Given this list of marker genes Commd1, Gm15418, Prnd, Fam47e, Gm22206, Lrfn2, Yars2, Pcdhb22, Celsr2, Mertk, Tns3, Ric8b, Crybg2, Dcst1, Ttll6, Zcwpw2, Tap2, Polr1f, Farp1, Nedd4l, Brpf1, Tle1, Vwf, Atad2b, Ccdc12, Dennd10, Tgfb3, Ndufs6b, Nme1, Gm12315, Stimate, Smim45, Gm13974, Gadd45b, C2cd4b, Kifc3, Calhm5, Iqcg, Epb41l4a, Tm4sf5, Snrnp35, Gm26436, Gm9385, Gcc1, Cog1, Eif1b, Dclre1a, Gm49405, 1700003M07Rik, Syn3, Ccny, Zfp74, Enho, Pfkfb3, Cnnm2, Odad3, Abca4, Npr1, Spata3, 4930412C18Rik, Gm12034, Serhl, Cep135, 1700072G22Rik, Rnf139, Dalrd3, Parp3, Rnasel, Gm11725, Zfp143, Gm6610 (NCBI Gene Id 634864), Gm25604, Pts, Lcp1, Gart, Exosc4, Sh3bgrl2, Sbk2, Htr1a, Trappc3, Zc3h14, Aatk, Atp1b3, Ash2l, Ido2, Alg9, Ncmap, Gm5432 (NCBI Gene Id 432636), Pcdhb19, 2310001H17Rik, Spef2, Esr2, Chtop, Faxc, Snai1, Gm3809, Samd9l, Dlgap5, Chmp1b2, 4930432E11Rik, Tpm1, Pcdhac1, Bdh2, Txlnb, Ube2g2, Cebpd (NCBI Gene Id 12609), Morc1, Selenom, Enc1, Ube2l6, E330013P04Rik, Hsd17b14, Tnni3, Limch1, Sgk1, Eva1c, Ppp1r37, Ddah2, Ltbp1, Scara5, Txnrd2, Gm22018, Pou2f2, Mrpl17, Marchf11, Spc24, Nsfl1c, Pcgf1, Lrig2, Smarce1, Dpp6, Grik4, B230207O21Rik, Tsc22d3, Clcn2, 9530052E02Rik, Wdr41, Cfap100, Brf1, Hoga1, Ypel1, Kcna7, Slc6a21, Ppdpf, Slc38a10, Unc45a, Gm23946, Trex1, Gda, Slc25a45, Smim11, Amz2, Gnl3l, Prdm1, Nlgn1, Tmem82, Pdxdc1, Esf1, Gm16271, Adra1d, Gm23432, Sec14l2, Sft2d1rt, Cic, Arl1, Pcp4, Ror1, Gpaa1, Adam33, Dram1, Trim45, 9130213A22Rik, Prcp, Cmss1, Gm12514, Trpc3, AW495222, Nes, Grin2c, Pknox2, Lingo1, R3hdm1, Tekt5 (NCBI Gene Id 70426), Top1mt (NCBI Gene Id 72960), Gm23440 (predicted gene, 23440), Ago2, Ephb6, Yjefn3, Srcin1, Krtcap2, Gm25261, Nrxn2, Grep1, Mfsd4b4, Furin, Fbxo8, Pear1, Gm31243, Aadat, Arf4, Casp2, Styk1, Pgam5, Ulk1, Smarca5, Gm34767, Setd5, Gramd1b, Mpo, Btbd16, Rwdd3, Myg1, D6Wsu163e, Nkain2, Slc2a1 (NCBI Gene Id 20525), Alkbh7, Itga6, Raf1, Olfml3, Arhgef2, 0610031O16Rik, Gm12712, Ppp2cb, Traf5, Pcdhga10, Col1a1, Med23, Ggt7, Yju2b, Parp11, Atp7a, Mapkbp1, Hook2, Sag, Acin1, Ap5s1, Cfap46, Gm13031, Hhat, Tmem14a, Zdhhc1, Kif26a, Arrb2, Uqcc2, Tsc22d1, Ror2, Rtl9, Gm14017, Gm17952, Hivep3, Iqsec1, Cpne5, Gbp5, Cntfr, Ube2l3, Ect2l, Gm25148, Ttc19, Zfp607b, Hapln2, Adgra2, Garem1, Lmna, Psmc4, Gm26104, Smc3, Tafa2, Gm18036, Brsk2, Ywhae, Garin1a, Ttpal, Ush1g, Gm17552, Ephb1, Med27, B4galnt1, 1700069L16Rik, Gm37885, Tmem242, Tmem259, Npy1r, Ttc39a, Dgcr6, Tor2a, Ghr, Hgfac, Cryba2, Fam83h, Rhof, Slc9a1 (NCBI Gene Id 20544), Slc6a19, Ptpn22 (NCBI Gene Id 19260), Sigmar1, Csrp1, Adamtsl5, B9d1, Dus2, Gbf1, Sorcs2, Gpr108, Catip, Zyx, Tent5d, A230077H06Rik, Gm24469, Dst, Endov, Cacna1s, Emg1 (EMG1 N1-specific pseudouridine methyltransferase), Xndc1, Timm23, Akap7, Ppp1r14a, Ncf4, Elob, Dohh, A330023F24Rik, Tent4b, Cep44, Mir449c, Zfpm1, Lix1, Itga4, Ercc4, Mink1, Man2b2, C1ra, Gm34583, Apobec3, C030014I23Rik, 4930509H03Rik, Trim30b, Csmd3, Tnfaip8l2, Sema4f, Nfkbil1, Zzz3, Rusc1, Col26a1, Irak2, Harbi1, Nme9, Gnptab, Ncoa2, Pitpnm1, Gm35507, Rnf43, Zfp1004, Itgal, Cdh24, Cblc, Gm11342, Sh3d19, Fam171a2, Gm20610, Hsd3b7, Zfp51, Slc52a3, Gm17767, Tbc1d1, Faap20, Ints14, Ddx54, Gm22778, Caskin2, Rrp9, Nucks1, Icam2, Cabp2, Cfap54, Prp2rt, Ppip5k1, Gtf2ird1, Glis2, Npas2, Atf7ip, Gm22827, Adra1b, Atg101, Tmcc2, Cep164, Rapgef3, Slc35f1, Prorp, Acbd4, Mcmbp, Asb4, Piezo1, Fabp12 (NCBI Gene Id 75497), Timm22, Cdk5rap3, C1rl, 2310069B03Rik, Gm18444, Urod, Aox3 (NCBI Gene Id 98316), Rgs9, Lsmem1, Gm7168, Haus7, Tmem40, Gm13832, 9430087J23Rik, Smagp, 2600014E21Rik, Anapc7, Kmt2b, Acvr1c, Yipf6, Gins4, Dap3, Smg9, Shank3 (SH3 and multiple ankyrin repeat domains 3), Magohb, Zim1, Rnps1-ps, Ms4a19, Gm8501, Or52n4, 4930402F06Rik, Itga8, Islr2, Scarb2, Slc2a4, Septin9, Wnt7a, Exoc1, Mc5r, Plxna2, Atp8b5, Kctd15, 4930447M23Rik, Erap1, Dxo, Glipr2, Gimap8, Adap1, Atf6, 9930004E17Rik, Gm11175, Slc1a2, Gm2287, Rcc2, Gm10143, Sik2, Srl, Gm3336, Zfp868, Socs3, Gm11196, Gm4775, Tmem163, Frs3, Pcdhb16, Yars1, Acap3, Gm9936, Tsc22d4, Tyw5, Rbm4b, Eci2, Tctn1, Plk2, Gm23745, Pklr, 1600014C10Rik, Scgb1c1, Adra2b, Klc2, Rapgef1, Tlcd1, Rxfp3, Hoxc10, Sema3b, Mecr, Trav8d-2, Pde12, C330018A13Rik, Gm22881, Eif2b1, Palld, Kdm1b, 4930503O07Rik, Atp6v1g2, Ehd2, Ankrd44, Lsm11, Gm13025, Nav1, Ddx24, Armc8, Gh, Frg1, Dusp23, Gm15958 (NCBI Gene Id 100503546), Angel2, Mif-ps6, Capn8, Man2a1, Grin2b, Gm25758, Rp31-ps19, Ccdc42, BC028471, Dhx32, Gm25093, 4930519G04Rik, Gm42579, Pdgfrl, Atp2c2, Pafah2, Rab27a, A430048G15Rik, Pde4d, Tbl3, Gm17382, Ess2, Crybg1, Hipk4, Cenpx, Mir6380, Atp5f1d, Pcdh1, Gadd45g, Gm2093, Stk19, Mir7055, Iscu, Rbm3os (RNA binding motif protein 3, opposite strand), Tnk2os, Abt1, Gm13388, Zfp949, Gm20655, Vcan, Ezh1, Tmem108, Trgv7, Prr33 (NCBI Gene Id 677289), Cc2d2a, Ppp2r3c, Reln, Lpin3, Gm12273, Unc13b, Kctd18, Sult6b1, Ccbe1, Atp2c1, Lrrc24, Cyp2w1, Rbp7, Esyt2, Gstm1, Mnd1, 4930568A12Rik, Gm14010, Myo7a, Abca14, Gm28513, Thumpd1, Tmem220, Noc4l, Rnf150 (NCBI Gene Id 77483), Trpm5, Blcap, Cstdc2, Gm22245, Gm19412, Mllt1, Fgd6, Zcwpw1, Gm9701, 4930597A21Rik, Gmfg, Trav3-4, 1700109G15Rik, Slc6a8, Trmu, Prss48, Napa, App, Slco3a1, Zfp746, Gjc2, Ccdc88c, Alcam, Ciao3, Nup133, Nudt17, Slc5a8, Ctnna3, Gnaz, Epb41l4b, Wnt11, Nufip2, 4930451I11Rik, Klhdc9, Mir2861, Tinf2, Gas2l1, Gm9005, Gtf2h3, Mettl21a, Fmnl3, Gnas, Elf3, Ccr5, Gm25938, Dhx57, Tsga10, Diaph1, Rgcc, Acot11, Mir193a, Nr1i2, Gm26911, Camkk2, 1700001L05Rik, Slc23a2, Park7, Megf10, Hdc, Nop14, Bmp1, Gm43464, Polr3gl, Ighv1-86, Wdr38, Ctu2, Afp, M6pr, Senp3, Zfyve27, Adprs, Gypa, Snrpe, 1700007F19Rik, Gm8146, Bcl2l1, Gtf2h2 (general transcription factor II H, polypeptide 2), Plcb1, Cystm1, Gm13652, Tysnd1, Gm29610, Clec4d, Ciart, Srbd1 (NCBI Gene Id 98081), Nfx1, Gas7, Fgf15, Ap2s1, Glipr1l1, Mtnr1a, Fam136a, Zfp800, Cdk18, Mbip, Vps13d, Prkag2, Cfap97d1, Ankrd2, Tmc8, Pkn3, Flnb, Bltp2, Idh1, Trappc3l, Nob1, Grn, Gm10253, Edn1, Il20ra, Mrpl38, Spmap2, Map3k6, Psg16, Mcm5, Ppm1j, 1700028E10Rik, Irf7, Gm2109, BB014433, Arhgef10l, Spen, Gm23856, Cideb, Ddo, Tdrd5 (tudor domain containing 5), Arhgef16, Coa7, Rgs20, Drd1, Tsen54, Crip1, Poc1a, Lrrc7, Bmal1, Ctsr, Gm26812, Gm42922, Gm16184, Rbfox3, Flvcr1, Gm24334, 2410004B18Rik, Tgfb1i1, Asnsd1, Rubcnl, Pdlim2, Gm4279, Brd10, Clu, Mir3960, Eif3f, 1700072B07Rik (NCBI Gene Id 73529), Cpt2, Comtd1, Fbl, Dnmt3b, Ddias, Zfp692, Son, Ccdc13, Cacnb3, Ctnnb1, Prss36, Parl, Lsr, Gm33051, Nifk, Gfi1b, Coro2a, Atg13, Spns1, Cmah, Carmil1, Adra2a, Cemip, Gm14161, Parm1, Ryr2, Ccdc153, Ggnbp2, Tmem33, Lgi4, Rtn4r, Mir6919, A230108P19Rik, Dixdc1, Mlf2, Gm15401 (NCBI Gene Id 100038714), Ankmy2, Slc25a38, Pold1, Scnn1g, Rhoay-ps3, Sds, Mgat5b, Chrm5, Rbak (NCBI Gene Id 57782), Timm9, Fancc, Telo2, Nepro, Sema3f, Scai, Pfn4, Eid2b, Bambi, Gm11532, Ankrd6, Sfswap (NCBI Gene Id 68937), Phlda1, Apmap, Gdf5, Wdr83, Tnnt3, A830082K12Rik, Rnd3, Gm26885, Clcc1, Gm10610, Katnal1, Rpl21-ps11 (NCBI Gene Id 433630), Pcdhb14 (protocadherin beta 14), Gm16133, Col23a1, Rbis, Gbp3, Lhfpl7 (NCBI Gene Id 333048), Erlin2, 2410004P03Rik, Usp38, Elf5, Pld2, Snx15 (sorting nexin 15), Reep4, Pak4, Gm29704, Nlrx1, Hnrnpm, Ankrd39, Magi2, Tbc1d9b, Gm11100, Arhgap26, Slc35e4, Foxs1 (forkhead box S1), Adamts17, Cyp21a1, Gm25631, Zfp663, Slc7a7, A630001G21Rik (NCBI Gene Id 319997), Lrrc3c, Gm10825, Gad1, Trim69, Cln5, Man2c1, Pink1, A730011C13Rik, Dnajc13, Amigo3, Edrf1, Mup-ps17, Flot1, Gm20658 (predicted gene 20658), Gm22927, Olfm1, 1700047G03Rik, C2cd3, Rad51d (NCBI Gene Id 436461), Rpp30, Lyzl6, Ski, Slitrk5, Cfap157, Gm831, Tmem11, Lrrc27 (leucine rich repeat containing 27), Ache, Tmod2 (tropomodulin 2), Nckipsd, Zc3h6, Sphk1, Arhgap22, Gm26352, Trip10, Cryzl2, Ovca2, Gm16144, Rmnd5a (NCBI Gene Id 79046), Arl4aos, Gars1, Agpat3, Rcc1, Cyp21a2-ps, Cd164, Gm20443 (NCBI Gene Id 118568333), Kyat3, Pou2f1, 1700128E19Rik, Sult1d1, Gpx8, Gm4925, Dact3, Msantd1, Npdc1 (neural proliferation, differentiation and control 1), Gm11444, Nmbr, Best1, Cul9, Itga9 (NCBI Gene Id 70107), Car2, Rpl5-ps2, Gm28836, Erich2, Arhgap18, Zng1, Rpgrip1, Cabin1, Mterf1a, Mir187, Cdc14b, Adcy10, Gpsm1, Pdgfra, Bach2os, Tph1, Gm40332, Dcaf11, Suds3, Nudt1, Sox13, Stum, Gm17508, Csgalnact1, Pdhb, Pdzd9, Pitpnm3, Gm9978, Slc25a22, Gm15408, Bcl6b, Vta1, Abcb8, D330050G23Rik, Abr, Plxnb2, Alox12e, Sh3kbp1, Wdr1, Mir7672, Mir497, Sec11c, Cbarp, Ubxn11, Fntb, Atp2b4, Chrna1os, Lbh, Snx18, Nbeal2, 4632415L05Rik (RIKEN cDNA 4632415L05 gene), Chrdl2, Gm9929, Eid2, Lrrc66, Gm14330, Etv5, Kcp, Trmt61b, Hmgb1-ps6, Tmem200a, Twf1, Gm23748, Otop2, Gm42935, Mir6944, Ahcyl1, Tomm5, Tbx3os2, 1810044D09Rik, Ttc24, Cgnl1, Rtn4rl1, Gm11998, Tshr, Mc3r (NCBI Gene Id 17201), Smim29, Map4k5, Kcnk13, Mir8109, Arl4a, Pag1, Cog4, Ephb3, D5Ertd615e, Snx14, Aire (autoimmune regulator), Gse1, Ccin (NCBI Gene Id 442829), Dnai2, Ppp1r9a, Notum, Tmem102, Gm12494, Fgd5, Gm25726, Alkbh4, Rita1, Pias3, Gm10039, Ptpre, Vezt, Spry4, Znrf1, Man2c1os, Txndc5, Coq8b, Glra2, Ninj2, Focad, Dcbld2 (discoidin, CUB and LCCL domain containing 2), Cdk9, Inka1, Mir759, Mmp17, Capg (NCBI Gene Id 12332), Trpv2, Crbn, Gm30382, Tcerg1l, Elmo1, Gm9989, Ppox, Atp8b2, Chct1, Psmc3, Gm26225 (NCBI Gene Id 115488410), Phf8, Gm3764, Ccdc177, Bid, Trappc5, Adam15, Npff, Gabpb1, Dtx4, Gm12925, Gm26802, Gm38171, Rtca, Ptpru, Mfsd4b3-ps, Gcnt1, Mir7653, Socs1, Fmnl1, Carf, Commd7, Cpeb1, Cenpu, Kcnj6, Asic5, Tedc1, Taf1c, Fkbp14, Rufy4, Sptan1, Mrgpre, Mir669n, 1700054O19Rik (NCBI Gene Id 74272), Sdk2, Rnf7l, Idua, Gm10224, Steap1, Pcdha12, Hoxd3os1, Timm44, Spr-ps1, Rnf123, Rbpms (RNA binding protein gene with multiple splicing), D930020B18Rik, Gm1720, Rapgef4os1, Rprm, Efna1, 0610040F04Rik (NCBI Gene Id 75394), Acacb, Clip1, Gm26406, Ndor1, Csnk1a1, Mycn, Sec31a, Mro, Myof, Podxl2, Camk1d, Ftx, Nemp2, Pxn, Robo3, Tfip11, Tph2, Kdm2b, Mir100hg, Mogat1, Cirbp, Rnd2, Igsf9, Uba1, Klf13, Fryl, Gm6361 (NCBI Gene Id 632710), Gm30484, Megf8 (NCBI Gene Id 269878), Pidd1, Fam222a, Azi2, Suox, Slc39a13, Mmp9, Ctdsp1, Hoxa7 (NCBI Gene Id 269740), Cacna1e, Bscl2, Ptpn18, H4c11, Zpbp2, Hcar1, Rab37, Ptpa, Otos, Cpne4, Gm23774, 6530411M01Rik, Sgf29, Gm42109, Zfp345, Ntrk1, Grk5, Pik3r5, Armc6, A930015D03Rik, Gm11420, Mipol1, Trp53rkb, Gm8186 (predicted gene 8186), Gm24335, Prkcz, Map3k5, Atp9a, Ramp1, Gm25009, Hcrtr1, Katnbl1, 2010204K13Rik (NCBI Gene Id 94037), Gm29387, Nelfa, Ndufaf6 (NADH:ubiquinone oxidoreductase complex assembly factor 6), Pdgfd, 1700045H11Rik, Scn3a, B3gnt3, Gm7094, Afap1l2, Epha1, Tgif1, Rad51ap1, Smarcd3, Rab13, Slc22a15, Exd1, Cebpb, Nup42, Tlr6, Myo18a, Rpl7l1, Etos1, Dhx30, Mrpl52, Gm16459 (NCBI Gene Id 671250), Czib, Notumos, Tnfrsf21, Gng7, Gm23437, Sell, Rhcg, Slc16a11, Ccdc192, Gap43, Kdm6bos, Pga5, Bzw2, 4632404H12Rik, Hsp90aa1, Alpl, Dip2b (disco interacting protein 2 homolog B), Rtn2, Gm32585, Pcdhga11, Tnfaip3, Grk2, Gm12411, Aipl1, Gm27008, Wif1, Pex10, Airim, 4833412C05Rik, 9330175M20Rik, Cep63, Pla2r1, Clec4g, Rai1, 1500015L24Rik, Pvr, Tank, Cilk1, Ceacam23, Tmem270, Npc1, Prkcsh, Etv4, Rnf215, Cdh23, Car5a, 1700030A11Rik (RIKEN cDNA 1700030A11 gene), St8sia1, Gm36070, 2410124H12Rik, Synj2, Arhgap27, Rasd1, Cyp2j15-ps, Mfhas1, Itih1, Sgsm3, Cxcr4, Slc36a1, Pdk2, Ube4a, Mttp (microsomal triglyceride transfer protein), Adam11, Mrpl39, C1qtnf1, Stag1, Gm24998, Eif2ak1 (NCBI Gene Id 15467), Gm43380, Gm15651, Npl, Etnk1, Mettl2, Prickle4, Rbm17, Kirrel1, Hectd3, Adgre5, Rbm46, Cntn2, Eif4g2, Mep1b, Spmip7, Larp7, Zfp36l1-ps, Astl, 1700034H15Rik, Gm18330, 4930573C15Rik, Clec2d, Oma1, Psen2, Srsf3, Ccdc38, Spata20, Tmem191 (NCBI Gene Id 74063), Rac3, Nt5c1a, Pigz, Rnf166, Gm13506, Gm24580, Pex1, Plekhg2, Gm24751, Gm3086, Gm4784, Mir195a, Irag1 (NCBI Gene Id 233729), Gm11378, Ablim1, Lrrc15, Amdhd1, 4930463O16Rik, Stk10, Sema3c, Slitrk6, Gm24433, Fuca1, Mfsd4a, Trpm8 (transient receptor potential cation channel, subfamily M, member 8), Atp11a, Pou2f3 (NCBI Gene Id 18988), Mir7235, Snord3b-ps2, Rrp1, Gm11638, Ppp1r12c, Ctc1, Sh3bp5, Scn2a, Tns1, Socs2, Zfp638, Ccng2, Cemip2, Fam185a, Ccdc85a, Slc29a1, Mob3b, Slc12a9, Trmt1, Chd9, Gm12069, Gm25345, Gna14, Tfap2c, Zfta, Ube2q1, Rnf19b, Cdkn2aipnl, Lig4, Rbm3-ps, Cxcl3, Rab32, Trim46, Antxr1, Hoxc5, Inpp4b, Asgr1, Cldn1, C1rb, Phlpp1, Dnm3, Prlr, D5Ertd605e, Atl1, Dhx8, Nectin2, Mroh7, Nuf2 (NCBI Gene Id 98608), 4930521E06Rik, Dusp13b, Chadl, Dpysl3, Inafm2, Coq2, 5033423K11Rik, Ablim3 (actin binding LIM protein family, member 3), Ahcyl2, Mycl, Nsg2, Rpl18a, Gm24794, Dnah17, Sh3glb1, Mrpl33, Ccdc83, Plekha6, Gm5614, Gnai2, AA474408, Myo1h, Galt, Gm23609, Tmem42, Cdkn2a, Vsir, Elapor1, Fmod, Vegfa, Rpl13a, Gm26671, Tmem199, Gm11465, Ripor2, Med12, Tex48, Slc38a8, 2310015A10Rik, Setd1a, Ddx51, Gm650, 2700049A03Rik, Errfi1, Cfap276, 4930447F24Rik, Sucla2, Zfat, Nceh1, Tent5b, Abca15, Pcyt2, Mafb, Pcdhgb7, Zfp469, Lgr6, Dop1b, Ccdc124, Otud5, Coro7, Pcdhb21, Nhlrc2, Pcdhgb8, Gm11422, Gm24457, Adprhl1, Ahrr, Cntrl, Nprl3, Vps18, Grm8, Prodh2, Gm12602, Uck1, Phb2, Zfp54, 0610040J01Rik, Kcnh1, Gfap, Gm12320, Mir1668, Ifngr2, Spock1, Gask1b, Hnrnpd, Mfn1, Atn1, Gm24793, Gm13778, A830008E24Rik, Col6a2, A330048O09Rik, Plxna1, Cuedc1, Chp1, 4921539H07Rik, Gm11954, Fhod3, Fcmr, Rps19-ps10 (NCBI Gene Id 676683), Dnajc22, Zfp764, Als2, C3, here is a description of the gene set: Genes containing one or more binding sites for (Zc3h11a) in their promoter regions (TSS -1000,+100 bp) as identified by GTRD version 20.06 ChIP-seq harmonization. studied in species Mus musculus Mouse Gene Set: ZC3H11A_TARGET_GENES from publication Yevshin I, Sharipov R, Kolmykov S, Kondrakhin Y, Kolpakov F (PMID 30445619)